Given this list of marker genes Rnf122, 5730437C11Rik, Ppp1r9a, mt-Nd1, mt-Ta, Rhob, Etv4, Zc4h2, Fam98b, Gm12108, Hibadh (3-hydroxyisobutyrate dehydrogenase), Skap1, Crlf2 (NCBI Gene Id 57914), Gm16141, Lta4h, Hoxd4, Fgf7, Pde9a, Mrpl3, Tmem267 (transmembrane protein 267), Rsrc1, Dynll1 (dynein light chain LC8-type 1), A930015D03Rik, Gm22863, Fggy (FGGY carbohydrate kinase domain containing), Ptk2, Ing3, Hmox1, Rbm25, Lrrcc1, Csrnp3, Fmc1, Gm16251, Zfp607b, Gm24576, Ephb3 (NCBI Gene Id 13845), Trim23, Phpt1 (phosphohistidine phosphatase 1), Snx30, Ss18l2, Trerf1, Sec22b, Gm20714, Mtmr11, mt-Tc, mt-Tv, H4c16, mt-Ti, Tcf4, Mid1, Pkia, mt-Tl1, Gm25296, A430105J06Rik, mt-Tm, Gli2, 1700096K18Rik, Hoxa9, Rbpms, mt-Tn, mt-Rnr2, Katnip, Haus4, Tia1, Ppp2r3d, Hexd, Gm22203, Tmem259, AU020206, Gm11587, Gm43391, Sumf1, Mpp3, Smarcal1, Spata31e2, Khdc4, P3h2, Slc38a2, Plpp3, Rack1, Slc7a1, Zfp960, Trib2 (tribbles pseudokinase 2), Hes1, Fry, Rad54l2, Eif3c, mt-Ty, Gm10637, Gnpda2, Parva, Pitx1, Rnf220 (NCBI Gene Id 70613), Hoxd3, Esrrg, Meis1, Wdfy1, Srpk2, Lrrfip1, Eif2s3x, Trappc13, Med23, Adipor2, Tgif1, Auts2, G530011O06Rikx (RIKEN cDNA G530011O06 gene x), Pex3, 9530003O04Rik, Gm13179, 4930445N18Rik, Cachd1, Actn4, Gm13421, Uba1, Gm37450, Itln1, Gm10222, Caml, 9330111N05Rik, Gm20788, Men1, Gm36241, Map3k11, Lars1, Gm26839, Ric8b, Galnt7, Gm11217, Msrb3, Duxf1, Gm36520, Gm15247, Rgma, mt-Td, Gm14401, Sema3a (NCBI Gene Id 20346), Tenm3, Mrpl44, Msh5, Rrp15, Zfp998, Ttll11, Tmem97, St3gal4, Hoxa7, Exoc1, Ppp1r37, Ttc28, Itch, 4930581F22Rik (NCBI Gene Id 78934), Mamdc4, Mybpc1, Hoxa3 (NCBI Gene Id 15400), Rora, Mir5129, Mir615, 3110070M22Rik, Mnat1, Pcnx3, Nr6a1os (nuclear receptor subfamily 6, group A, member 1, opposite strand), 1600014C10Rik, Gtf3c3, Zfp945, Nop53 (NCBI Gene Id 98700), mt-Nd2, E4f1, Usp40, Rtcb, Ift46, Gm5432, Speer4cos, 2610300A13Rik, Mapkapk5, Pax2, Gask1b, Gm4665, Gm25541, Mrpl33, Gm15478, here is a description of the gene set: Mouse Gene Set: HOXC10_TARGET_GENES Genes containing one or more binding sites for (Hoxc10) in their promoter regions (TSS -1000,+100 bp) as identified by GTRD version 20.06 ChIP-seq harmonization. studied in species Mus musculus from publication Yevshin I, Sharipov R, Kolmykov S, Kondrakhin Y, Kolpakov F (PMID 30445619)